Given this list of marker genes Hs3st1, Zfp1, Sesn1, Cd83, Ccnd3, Ptpn22, Ncl, Syngr2, Mettl1, Dhx40, Pdcd4, Sorl1, Pag1, Nme1, Ly6a, Fxr1, Ssh2, Arap2, Apobec1, Foxn3, Alkbh1 (alkB homolog 1, histone H2A dioxygenase), Acp5, Egln2, Tbc1d15, Cebpb, Odc1, Serinc3, Stat1, Napsa (napsin A aspartic peptidase), Cytip, Scd1, Zbp1, Ptprj, Sema4b, Pkig, Gpr171, Tsc22d3, Hcls1, Bcl3, Ptpn1, Zfp36l2, Irgm1, Hspa9, Ranbp1, Irf1, Cd38, Spcs2, Mrpl52, Ifi47, Socs3, Ccnd2, Adrb2, Ppp1r21, here is a description of the gene set: from publication Cui A, Huang T, Li S, Ma A, Pérez JL, Sander C, Keskin DB, Wu CJ, Fraenkel E, Hacohen N (PMID 38057668) studied in species Mus musculus Mouse Gene Set: CUI_B_CELL_IL1A_RESPONSE_UP Genes positively differentially expressed in cell type: B cell upon treatment with cytokine: IL-1α in mouse lymph nodes in vivo. Cytokines mediate cell-cell communication in the immune system and represent important therapeutic targets. A myriad of studies have highlighted their central role in immune function, yet we lack a global view of the cellular responses of each immune cell type to each cytokine. To address this gap, the authors created the Immune Dictionary, a compendium of single-cell transcriptomic profiles of more than 17 immune cell types in response to each of 86 cytokines (>1,400 cytokine-cell type combinations) in mouse lymph nodes in vivo. A cytokine-centric view of the dictionary revealed that most cytokines induce highly cell-type-specific responses. For example, the inflammatory cytokine interleukin-1β induces distinct gene programmes in almost every cell type. A cell-type-centric view of the dictionary identified more than 66 cytokine-driven cellular polarization states across immune cell types, including previously uncharacterized states such as an interleukin-18-induced polyfunctional natural killer cell state.